The following is a description of a gene set: Catalysis of the transfer of NEDD8 from one protein to another via the reaction X-NEDD8 + Y = Y-NEDD8 + X, where both X-NEDD8 and Y-NEDD8 are covalent linkages. studied in species Homo sapiens Human Gene Set: GOMF_NEDD8_TRANSFERASE_ACTIVITY, and this is the list of marker genes: UBE2M, UBA3, MDM2, UBE2F, RBX1, RNF7